Given this list of marker genes FGF6, ASPH, KCNN1, PAK6, KRT222, TENT5A, RIPOR1, HOXB4, TSC1, PRKAG1, GNAS, CDC42EP3, UBE3A, MAS1, LUZP1, MEF2C, JCHAIN, TPM2, KLHL20 (NCBI Gene Id 27252), TSC22D1, ARHGAP36, KCNJ9, WNT8B, GRK7, LMCD1, TRIM8, UBFD1, ATL2, CAPN1, ZNF362, FOS, LYN, GRAP2, TRIM55, BEST3, ASCL2, JPH2 (junctophilin 2), TSPEAR, ACAP2, MYL1, SYT10, SSPN, KRT83, CDIN1, NEDD4, ZNF516-DT, IL17B, GET4, LHFPL3, EPHB1, WFDC1, UBXN10, ZFPM2, ZIC4, ESRRG, HAPLN1, DMP1, MYL2, NDP, SMAD1, GTF3C3, ANP32A, MYH6, USP47, SMARCA1, ANK3, ELMO3, ARRDC3, NCAN (NCBI Gene Id 1463), MSX2, SPIC, KCNK9, GRIK1, ITGB6, TBC1D16, SOX14, EHBP1, FGF12, ARHGEF15, AKAP12, RAB20 (NCBI Gene Id 55647), MYO18A, TNNC1, AKAP13, JUN, DLL4, ZBTB18, MYOZ2, ZNF281, PTCHD4, PHOSPHO1, AICDA, SMPX, MLF1, CA7, NFIX, PDGFRA, C12orf50, S1PR1, CKM, SLC12A5, ITGB3BP, HOXA10, CDC25B, HDAC9, SLC26A9, GPC4, TIMP2, CASQ2, SOBP, LINC01597, TRDN, C12orf42, RIMS2, CRP, MPC2, SESN3 (sestrin 3), MBNL2, TNNI3K, SYT16, CKMT2, EYA1, SH3BGRL, COL13A1, ZNF385B, ITGA7, ABCA8, HOXA3, BMP7, PRMT3, TTYH2, GATA4, S100PBP, FBXO40, ZC3H11A, DPYSL3, SOX2, SLC7A9, AGGF1, AGTPBP1, HAS2, SYNPO2L, CNGA1, CACNA2D3, BEGAIN, SMARCA2, MYO9A, HS3ST5, DKK1, here is a description of the gene set: Human Gene Set: MEF2_01 Genes having at least one occurrence of the motif CTCTAAAAATAACYCY in the regions spanning 4 kb centered on their transcription starting sites. This matches the transcription factor binding site V$MEF2_01 (v7.4 TRANSFAC). studied in species Homo sapiens